Given this list of marker genes ZFP36L2, MFSD5 (major facilitator superfamily domain containing 5), REN, KLF5, FAM20C, GJA4, HES5, FAM151A, PLIN2, PCBP1, TRIM37 (NCBI Gene Id 4591), CKB, GFRA3, PSIP1, MVK, TBC1D1, EIF4A2, LMNA, TES, SCAMP2, TPD52L1, KCNQ2, TAPBP, REXO1, IRF8, CMPK2, NPC2, RAP1GAP, MX1, MYADM, LARP4B, KIAA0930, MAGOH, SMS, FUCA1, FRMD6, MFSD1, COLGALT1, DAP, RACK1, F11R, CBX7, PGRMC2, IRF7, CLDND1, VIM, RSAD2, PRUNE1, GRIN2A, ACAD9, KCNAB1, ST3GAL1, ST3GAL5, IRF9, GORASP2 (NCBI Gene Id 26003), TESK1, ISG20, PEX19 (NCBI Gene Id 7835), SYNGR1, LIPA, SRP68, ITGA4, MYOC, SSR3, TLR7, PAPOLB, ITGAX, BRI3, FBP1, MATN2, DAXX, SLC35E4, RNASET2, INSRR, VPS37C (NCBI Gene Id 55048), ATP6V1E1, ISCA2, TOR3A, HCLS1, PIGK, RHOB, REEP5, KRT12, RAMP2, IFIT2, GNAT1, LIMD2, TAP1, TAX1BP3, MAFK, PMP22, RNF123, NCF4, MAPK14, ESRP2, PPP3CB, PRPF6, IRF5, TP53INP2, BCL2L11, ARMC1, MADCAM1, MNS1, C1QB, PLXNA3, STX3, BLNK, COL2A1, SEC11C, GRIN2B, GGA1, E2F8, MEF2A, IDI1, RUNX1T1, STAU1, TRIM21, RESP18, AZI2, G3BP1, HPCAL1, AGRN, PRRC1, NSG2, PITPNC1, GNAI2, TMEM223, SRA1, UCP2, STK10, MX2, IRS1, TNFSF9, OPRK1, CLK2, MAP2K7, SNX21, TRIM25, DYNC1H1, CLEC4D, ABCC1, PSMB9, RBPJL, SUSD6, EPB41L1, CSF1R, NKX2-2, SF3A2, TOR1AIP2, NFKBIZ, VCAM1, CRLF3, MEF2B, SCHIP1, HDGF, RNPEP, SMAD3 (SMAD family member 3), LCP1, FAM107B, LGALS8, TNFRSF4, MEMO1, SLC25A48, PTPRCAP, CACNB3, GRAP2, GRB7, HLA-G, FBXO9, USP18, MRPL9, EIF1, GTF2B, POU2AF1, CCL22, STX6, ETAA1, TWIST1 (NCBI Gene Id 7967), SEMA5B (semaphorin 5B), PAX6, SREBF1, AKAP9, BCL2A1, WWTR1, UQCRC2, BRK1, EMC6, C9, CD2AP (NCBI Gene Id 25916), NUP54, ALCAM, DYRK1B, HSPA1B, ACKR3, ORC2, DCAF12, USP48, TRAF1, RHAG, SLC4A8, here is a description of the gene set: Human Gene Set: GSE43955_TH0_VS_TGFB_IL6_TH17_ACT_CD4_TCELL_4H_DN Despite their enormous importance, the molecular circuits that control the differentiation of Th17 cells remain largely unknown. Recent studies have reconstructed regulatory networks in mammalian cells, but have focused on short-term responses and relied on perturbation approaches that cannot be applied to primary T cells. Here, we develop a systematic strategy – combining transcriptional profiling at high temporal resolution, novel computational algorithms, and innovative nanowire-based tools for performing gene perturbations in primary T cells – to derive and experimentally validate a temporal model of the dynamic regulatory network that controls Th17 differentiation. The network is arranged into two self-reinforcing and mutually antagonistic modules that either suppress or promote Th17 differentiation. The two modules contain 12 novel regulators with no previous implication in Th17 differentiation, which may be essential to maintain the appropriate balance of Th17 and other CD4+ T cell subsets. Overall, our study identifies and validates 39 regulatory factors that are embedded within a comprehensive temporal network and identifies novel drug targets and organizational principles for the differentiation of Th17 cells. from publication Yosef N, Shalek AK, Gaublomme JT, Jin H, Lee Y, Awasthi A, Wu C, Karwacz K, Xiao S, Jorgolli M, Gennert D, Satija R, Shakya A, Lu DY, Trombetta JJ, Pillai MR, Ratcliffe PJ, Coleman ML, Bix M, Tantin D, Park H, Kuchroo VK, Regev A (PMID 23467089) Genes down-regulated in CD4 T helper cells (4h): Th0 versus TGFB1 and IL6. species: Homo sapiens